Given this list of marker genes Npy2r, Sncg, Syt1, Htr6, Abat, Smpd3, Drd2 (NCBI Gene Id 13489), Slc18a1, Park7, Syt4, Htr2a, Slc22a1, Drd1, Drd3, Gnat1, Slc22a3, Slc18a2, Grm2, Rtn4, Slc29a4, Entpd1, Syt11, Kpna4, Oprk1, Kcna2, Syt7, Tor1a, Chrna6, Htr1b, Cnr1, Pcp4, Myo5a, Xlr4b, Slc29a3, Gabbr1, Slc6a3, Tgm2, Chrna4, Prkn, Slc6a2, Snca, Nat8l, Dtnbp1, Prkcb, Xlr4a, Rab3b (RAB3B, member RAS oncogene family), Gdnf, Pink1, Cxcl12 (NCBI Gene Id 20315), Chrnb2, Chrm5, Mapk15, Comt, Rab3a, Slc22a2, here is a description of the gene set: studied in species Mus musculus The directed movement of dopamine into, out of or within a cell, or between cells, by means of some agent such as a transporter or pore. Dopamine is a catecholamine neurotransmitter and a metabolic precursor of noradrenaline and adrenaline. Mouse Gene Set: GOBP_DOPAMINE_TRANSPORT